The following is a description of a gene set: Mouse Gene Set: chr17B1 species: Mus musculus, and this is the list of marker genes: H2-T10, Flot1, Zbtb22, Zbtb12, 1110038B12Rik, Gm4252, Rpp21, Or10al4, H2-M11, Vps52, Gm8801, Btnl7-ps, Abhd16a, Wdr4, Clic1, Zfp955b, Stk19, Gm4246, Gm17782, Rps2-ps8, 4931413I07Rik, H2-M10.1, Gm8868, Mir6975, C2, B3galt4, Or1o3, Gm18604, Gm30571, Or11a4, Zfp472, 1700031A10Rik (NCBI Gene Id 73286), Mdc1, H2-M9, Or1o2, Rgl2, H2-Q7, Angptl4, H2-M6-ps, H2-M10.2, Stk19-ps1, D17H6S53E, H2-M10.6, Gm20513, 2310015A16Rik, H2-T11-ps, Gpank1, Gm4432, Rxrb, Akap8l, Gm18808, Zfp870, H2-DMb2, Trim26, Prrt1, Gm8877, Esp15, Nfilz (NCBI Gene Id 631604), Notch4, Esp23, Psors1c2, Or12d16-ps1, Zfp955a, Or11a3-ps1, Trim31, Gm19412, Or12d12, Gm15821, Gm6452, Or2b4, Apom, Or14q1-ps1, Notch3, Gm8810, 4833427F10Rik, Gm11131, Ager, Dhx16, AA388235, Gm18737, Ndufv3, Cyp21a2-ps, Ly6g6f, Morc2b, Or10h28, Pou5f1, Brd4, Gm18520, Smim40-ps, H2-Aa, Vhl-ps1, Or2g25, Ppp1r18, Gm7326, Gm5967, Gm7031, Or2h1b, Gm8750, Gm4134, Tubb5, Or14j3, Aif1, H2-D1, Slc44a4, Brd2, Pdxk-ps, Gm15321, Gm6726, Fkbpl, Wiz, H2-T13, Cyp4f40, Or14j7, Gm19807, Gm15331, Gm9613, H2-Ea, Gm4271, Adamts10, Gm8835, Or14j6, Mir8094, Cchcr1, H2-Pa, Cyp21a1, Rps28, Bag6, 2300002M23Rik, Esp38, Rab11b (NCBI Gene Id 320652), Gm8752, H2-T5, Mir6971, H2-M1, Or2n1e, U2af1 (U2 small nuclear ribonucleoprotein auxiliary factor (U2AF) 1), Muc21, Lta, Ly6g6e, A530088E08Rik, Abcf1, Ly6g6c, Zfp414, Cyp4f37, Esp22, Vars1, Gm18784, Gm8741, C4a (NCBI Gene Id 625018), Gm18273, Or5v1, H2-Q4, H2-Pb, Or14j10, H2-DMb1, Snord52, Tnxa, BC051226, Or2h1, Mpig6b, Pglyrp2, Ubd, Gm20541, Mucl3, Cd320, H2-Q3, Ddr1, H2-M2, Gm25128, Rnf5, Gm50050, Ppp1r10, Hsf2bp, Nelfe, Gm4577, Or12d14-ps1, Btnl5-ps, Phf8l, H2-Q6, Or2h2b-ps1, Or14j9, Gm18213, Cyp4f38-ps, Agpat1, Ppp1r18os, Or14j8, Cyp4f13, Skic2, Dxo, H2-T7 (histocompatibility 2, T region locus 7), Pde9a, Or11a5-ps1, Polr1has, Zfp811, Gm23442, 2310061I04Rik (RIKEN cDNA 2310061I04 gene), Gm25104, Sik1, Hsd17b8, Tap2, H2-Oa, Rrp1b, Atp6v1g2, Or14r1-ps1, Mir219a-1, Cbs, Gpsm3, Zfp563, Gm6659, Tap1, Ddx39b, Esp18, Mir6974, A930015D03Rik, Or2y3, Stk-ps1, Hspa1b, Mir877, Zfp952, Or2h15, Gm9574, Btnl6, Gm6633, Nfkbil1, Hspa1l, Ehmt2, Slc39a7, Egfl8, Atat1, Gm9902, Tnxb, Or10al7, Prr3, Vwa7, Btnl4, H2-T15, Mrps18b, Or2n1c, Gm17948, Zfp422-ps (NCBI Gene Id 100416808), Or11a2-ps1, Or10al2, Ier3, Or14j5, Sfta2, Or12d13, Gm18272, Or2g1, Ring1, Or10al6, Or2h2, Gm7059, Atf6b, H2-M10.5-ps1, Ppt2, Ly6g5c, Or1o4, Or2j3, Or10al3, H2-M5, Or5v1b, Ddah2, Gm10501, Cyp4f15, Mir6973a, Zfp101, Gabbr1, Ppp1r11, Or12d17, Ncr3-ps, Kank3, Gm18833, Mir1894, BC051537, Gm18733, Gm19553 (predicted gene, 19553), Ephx3, Trim40, Gm20522, H2-T3 (NCBI Gene Id 547339), H2-Q10, Cyp4f14, Col11a2, Psmb8, H2-M10.5, Gm8497, Gm6034, Gm4831, Zfp871, H2-Q5, Nrm, Gm20443, H2-Eb1, H2-M10.3, Gm25744, Zfp763, H2-Eb2, Ltb, Or1o1, Gm22589, Gm15320, H2-T23, Cdsn, Gm9577, Or10h5, Ly6g6d, H2-K1, Or2au1-ps1 (olfactory receptor family 2 subfamily AU member 1, pseudogene 1), Prrc2a, Esp16, Or14j4, Tsbp1, H2-M10.4, Or12d2, H2-M3, Ndufa7, Vars2, Or2n1b, Gm18734, H2-DMa, Gm8696, Or12d15, Cyp4f39, Gm23864, Gm4152 (NCBI Gene Id 105243785), Gm18268, Gm50105, Gm6623, Rpl9-ps5, Trim39, Or14j2, Lsm2, Pbx2, Gm16279, Sapcd1, Skiv2l-ps1, Or2g7, Mir6972 (NCBI Gene Id 102465587), Gm23294, Rps18, Hspa1a, Or14s1-ps1, Esp31, Or2n1, Psmb9, H2-Ob, Or1o11, Mog, Wdr46, Gm8878, Pknox1, 4833413E03Rik, Tapbp, H2-T22, Obox3-ps8, Smim40, Rbx1-ps, Lst1, Hnrnpm, Tnf, Gm17276, Zfp81, Neu1, H2-T24, Cryaa, Gm7335, Gm8815, Esp34, Pfdn6, Cyp4f41-ps, Rasal3, Gm5682, H2-Q1, Zfp799, Gtf2h4, Or2h2c, Mir219c, Rnf39, Esp24, Trim10, Rpl9-ps9, Or10c1, Daxx, Ly6g5b, Gm17115, Or10h1b, Cyp4f16, H2-Ab1, Cfb, Gm19684, Gm18522, Or10h1, Trim15, Myo1f, Gm25973, C4b, Kifc1, Or2n1d, Polr1h, Akap8, Pram1 (PML-RAR alpha-regulated adaptor molecule 1), Gnl1, Csnk2b, H2-T9, Tcf19, Btnl2, Lgals1-ps1, Or14j1 (olfactory receptor family 14 subfamily J member 1), Or2i1, Actl9, Gm10074, H2-Q2, Esp36, H2-K2, Marchf2, Btnl1, Or11a6-ps1, 2410137M14Rik, BC023719, Gm23111, Msh5, Rab11bos1, Cyp4f17, 2410017I17Rik, Zfp57, Or10al5